Given this list of marker genes SPAG5, NUF2, SPC24, AURKA, SPC25, PPP1CA, AURKB, CENPE, PPP1CB, NDC80, KNSTRN, PPP1CC, here is a description of the gene set: CENPE interaction with NDC80 complex. Pathway ID: N01531. Pathway type: Reference. Pathway class: nt06515 Regulation of kinetochore-microtubule interactions. Human Gene Set: KEGG_MEDICUS_REFERENCE_CENPE_INTERACTION_WITH_NDC80_COMPLEX studied in species Homo sapiens Pathway Definition from KEGG: (AURKA,AURKB) -| PP1 -- CENPE+(SKAP+Astrin) == NDC80C